The following is a description of a gene set: Human Gene Set: DURANTE_ADULT_OLFACTORY_NEUROEPITHELIUM_PLASMA_CELLS from publication Durante MA, Kurtenbach S, Sargi ZB, Harbour JW, Choi R, Kurtenbach S, Goss GM, Matsunami H, Goldstein BJ (PMID 32066986) species: Homo sapiens, and this is the list of marker genes: DERL3, IGHG1, PRDX4, CYBA, IGLC3, TNFRSF17, IGHA2, CD79A, IGKC, IGHG4, SSR4, IGHG3 (immunoglobulin heavy constant gamma 3 (G3m marker)), FKBP11, MZB1, HERPUD1, IGHA1, IGLC2, SEC11C, HSP90B1, JCHAIN, ITM2C